Given this list of marker genes Khk, Lipa, Smim14, Mvb12a, Ccnd1, Tmem221, Rpgrip1, Cd180, Fam117a, Runx2, Snx29, Ltb, H1f2, Ppfia4, Tsc22d1, Bri3, Lat2, Tmem163, Ptp4a3, Btg2, Myo5a, Cox7a2l, Spns3, Eif3e, Oxct1, Hs3st1, Smim5, Fyn (Fyn proto-oncogene), Zeb2, Bst2, Ighm, Sema4b, Klf2, Clec12a, Clec2d, Upb1, Atp1b1, Iglc3, Ctsl, Pold4, Sms, Pafah1b3, Bmyc, Timp2, Arhgap15, Ccr2, Ramp1, Gnas, Hexb, Rgs10, St3gal6, Cmah, Ripor2, Anxa2, Cdip1, here is a description of the gene set: Genes negatively differentially expressed in cell type: pDC (plasmacytoid dendritic cell) upon treatment with cytokine: IL-1β in mouse lymph nodes in vivo. from publication Cui A, Huang T, Li S, Ma A, Pérez JL, Sander C, Keskin DB, Wu CJ, Fraenkel E, Hacohen N (PMID 38057668) Mouse Gene Set: CUI_PDC_IL1B_RESPONSE_DN Cytokines mediate cell-cell communication in the immune system and represent important therapeutic targets. A myriad of studies have highlighted their central role in immune function, yet we lack a global view of the cellular responses of each immune cell type to each cytokine. To address this gap, the authors created the Immune Dictionary, a compendium of single-cell transcriptomic profiles of more than 17 immune cell types in response to each of 86 cytokines (>1,400 cytokine-cell type combinations) in mouse lymph nodes in vivo. A cytokine-centric view of the dictionary revealed that most cytokines induce highly cell-type-specific responses. For example, the inflammatory cytokine interleukin-1β induces distinct gene programmes in almost every cell type. A cell-type-centric view of the dictionary identified more than 66 cytokine-driven cellular polarization states across immune cell types, including previously uncharacterized states such as an interleukin-18-induced polyfunctional natural killer cell state. species: Mus musculus